The following is a description of a gene set: studied in species Homo sapiens Human Gene Set: GOBP_ATRIAL_SEPTUM_PRIMUM_MORPHOGENESIS The process in which anatomical structure of an atrial septum primum is generated and organized., and this is the list of marker genes: SOX4, ACVR1, GATA4, TGFB2, NSD2